Given this list of marker genes Tbcel, Tbcc, Tbcb, Tbcd, Tbce, Rp2, Tbca, here is a description of the gene set: species: Mus musculus Mouse Gene Set: GOBP_POST_CHAPERONIN_TUBULIN_FOLDING_PATHWAY Completion of folding of alpha- and beta-tubulin; takes place subsequent to chaperonin-mediated partial folding; mediated by a complex of folding cofactors.